The following is a description of a gene set: Genes positively differentially expressed in cell type: cDC1 (conventional dendritic cell type 1) upon treatment with cytokine: IL-15 in mouse lymph nodes in vivo. from publication Cui A, Huang T, Li S, Ma A, Pérez JL, Sander C, Keskin DB, Wu CJ, Fraenkel E, Hacohen N (PMID 38057668) Cytokines mediate cell-cell communication in the immune system and represent important therapeutic targets. A myriad of studies have highlighted their central role in immune function, yet we lack a global view of the cellular responses of each immune cell type to each cytokine. To address this gap, the authors created the Immune Dictionary, a compendium of single-cell transcriptomic profiles of more than 17 immune cell types in response to each of 86 cytokines (>1,400 cytokine-cell type combinations) in mouse lymph nodes in vivo. A cytokine-centric view of the dictionary revealed that most cytokines induce highly cell-type-specific responses. For example, the inflammatory cytokine interleukin-1β induces distinct gene programmes in almost every cell type. A cell-type-centric view of the dictionary identified more than 66 cytokine-driven cellular polarization states across immune cell types, including previously uncharacterized states such as an interleukin-18-induced polyfunctional natural killer cell state. Mouse Gene Set: CUI_CDC1_IL15_RESPONSE_UP species: Mus musculus, and this is the list of marker genes: Atp1b3 (ATPase, Na+/K+ transporting, beta 3 polypeptide), Sdc4, Snx6, Tpm4 (NCBI Gene Id 72202), Ppp1r2, Nmi, Tmem131, Sct (secretin), Irgm1, Anxa7, Cd274, Snx2, Sbno2, Cst3, Cd86, Gpr132, Il10ra, Cyria, Actr2, Rab5c, Ifi35, Reep3, Cd80, Gpr33 (G protein-coupled receptor 33), Ms4a6c, Parp14, Slfn5, Icam1, Hsd17b11, Tap1, Rrad, Pdk3, Slfn2, Procr, Traf1, Zfp318, H2-K1, Max, Sdc3, Gatm, Irf5, Casp1, Pgap2, Serpina3f, B2m, Zc3h12c, Cpne2, Aebp2, Cxcl9 (C-X-C motif chemokine ligand 9), Tent5c (terminal nucleotidyltransferase 5C), Ube2l6, Gng12, Bcl3, Tnfrsf1a, Ptpn1, Iigp1, Ildr1, Gadd45b, Cd38, Rap2a, Asb2, Trim30d, Ccl22, Txndc17, Rbms1, Larp1b, Clic4, Ly6e, Marcks, Pfkp, G3bp2, Ikzf2, Lamp2, Tmem184b, Phf11c, Ndrg1, Rsad2, Naa20, Rbm47, Psma4, Adam8, Nt5c3, Etv6, Rcn2, Cdc42bpg, Dnaja1 (DnaJ heat shock protein family (Hsp40) member A1), Trim30a, Kynu, Tmem219, Dennd4a, Esyt2, Snap23, Atp1a1, Casp4, Stat2, Nampt, Irf1, Cabp4, Armcx6, Picalm, Zc3h7a, Cpne3, Oas3, Basp1, Peli1, Irgm2, Cebpb, Irf7, Psmb9, Slfn8, Frmd4a, Plxnc1, Nabp1, Atp6v1d, Arf6, Stoml1, Arl5a, Ppm1k, Gramd2b, Gbp5 (guanylate binding protein 5), Lgals9 (lectin, galactose binding, soluble 9), Cyrib, Ifi205, Tor1aip2, Ciao2b, Ube2d3, Nfkbia, Atp6ap2, Rock1, Stx11, Fndc3a, Plgrkt, Rab10, Ifih1, Chd1, Spop, Klrk1, Il18, Lsm1, Sh3glb1, Arid5b (NCBI Gene Id 71371), Gfpt1, Ifi204, Apobec3, Cnp, Tnip3, Relb, Cd40, Cd53, Plaat3, Arrdc4, Itgb1, Gbp2, Il4ra, Plek, Fchsd2, Sell, Ifit2, Tpm3, Pttg1, Fnbp1l, Etnk1, Stat1, Tuba1a, Lgals3, Eif1, Daxx, Oasl1, Tor1aip1, Mab21l3, Mx1, Tapbpl, Pdcd10, Mcur1, Apol7c, Rigi, Cflar, Hif1a, Sri, Ifit1, Akr1a1, Cxcl16, Mthfd2, Usp25, Tmem131l, Dnase1l3, Nr4a3, Klf6, Marcksl1, Pml, Zc3h12d, Herc6, Sp110, Cmtm6, Ikzf1, Xaf1, Tcf7l2, Pkib, Ms4a6b, Gbp4, Rngtt, Bcl2l14, Sumo1, Cd8a, Kmo, Marchf5, Tes, Gca, Slc4a8, Nfkb2 (NCBI Gene Id 18034), Litaf, Crem, Isg15, Ctsz, Clec2d, Ccdc86, Rel (NCBI Gene Id 19696), Oasl2, Phf11a, Mcl1, Cd83, Mllt6, Prkx, Cdc14a, Rasgef1b, Lgals3bp, Slc8b1, Eif2ak2, Il15, Gbp3, Birc3, Slc6a6, Myd88, Helz2, Tagap, Mvp, Dock10, Rnf19b, Ctsc, Trib1, Lap3, Trim12a, Azi2, Timd4, Zyx, Spred1, Gyg1, Stxbp3, Avl9, Dtx3l, Tmed5, Socs1 (NCBI Gene Id 12703), Spi1, Slco3a1 (solute carrier organic anion transporter family, member 3a1), Lcp2, Pmepa1, Rap1b, Apol10b, Gbp7, Ppp1r11, Nras, Ppa1, Itga4 (integrin alpha 4), Lrrk1, Jak2, Zfand3, Nfkbie, Laptm4b, Tle3, Galnt7, Foxp4, Bbx, Smagp (small cell adhesion glycoprotein), Armcx3, Ifi44, Trafd1, Psma3, Ly6a, Fyn, Serpinb6b, Csf2rb, Psma7, Mkrn1, Usp15, Shisa5, Cd69, Mndal, M6pr, Denr, Mbd2, Dusp5, Tapbp, Csf2rb2, Ms4a4c, Tank, Ncoa7, Lfng, Fam241a, Ifi213, Ifitm3, Tpr, Il27, Cyba, Riok3, H2-T23, Larp1, Mpp1, Ifi207, Acer3, Pim1, Ifi203, Phf11b, Dnaja2, Dgkh, Zup1 (NCBI Gene Id 72580), Naa25, Srgn, Dhx58, Prdx1, Ifi47, Sting1, Acadl, Bcl2a1b, Ccr7, Glipr2, Parp12, Txn1, Atad1, Arhgap22, Csrp1, Isg20, Slc33a1, Tnf, Coro2a, Chmp4b, Bst1, Tor3a, Calhm6, Pnp, Ifi209, Znfx1, Fcgr4, Scimp, Rab8b, Ccnd2, Arhgap30, Aida, Fbxw17, Hnrnph2, Lyn, Ehd1, Npc2 (NPC intracellular cholesterol transporter 2), Bcl2a1a, Phf11d, Anxa4, Cttnbp2nl, Dync1h1, Wfdc17, Adap2 (ArfGAP with dual PH domains 2), Cd47, Slamf8, Sp100, Rnf213, Ogfr, Nudt9, Stat3, Cd24a, Parp9, Tgtp1, Cdkn1a, Atp6v1g1, Tspo, Samhd1, Bst2, Gripap1, Sp140, Rmdn3, Mxd1, Ptprc, Tax1bp1, Bcl9, Dusp2, Fgl2, Sppl2a (signal peptide peptidase like 2A), Usp18, Ifi211, Serpinb9, Tmbim6, Nlrc5, Abhd16a, Psmb10, Ece1, Tmem106a, Neat1, Flnb, Casp8, Etv3, H2-D1, Ilrun, Cct3, Psme2, Serpina3g, Ccnd1, Igtp, Vdac2, Atp8a1, Chd7, Arf4, Lmnb1, Gbp9, Cxcl10, Hivep2, Ccl12, Svbp, Gnb4, Parp11 (NCBI Gene Id 101187), Ly75, Cacnb3, Rasa4, Ggta1, Slfn1, Ifi27l2a, Ifitm2, Bcl2a1d, Rer1, Zbp1, Parp10, Gmppb